Given this list of marker genes PWWP2A, CHD5, H2BC12, PWWP2B (PWWP domain containing 2B), H2AJ, H2BC21, H3C1, CHD3, H2AC14, H2BC3, H2BC14, H2BC17, MBD2, H2BC5, MTA2, H3C15, H2AX (NCBI Gene Id 3014), MTA1, ADNP2, ZNF827, H2AC7, H2AC18, H2AC20, CBX1, H2AC6, ADNP, H2BC15, NR2F2, H3-3A, IKZF3, CDK2AP1, PHF6, MBD3L1, CHD4, G6PC1, H2AC4, H2AB1, H2BC12L, H2BC26, ZMYND8, H2BC9, ZNF687, H2BC4, MBD3L2, H2AZ2, SUMO1, CBX3, HDAC2, MTA3, MBD3, UBE2I, H4C1, ZNF592, IKZF2, NR2C2, RBBP7, CDK2AP2, ZNF532, PCK1, IKZF1, GATAD2B, GATAD2A, HDAC1 (NCBI Gene Id 3065), FBP1, H2BC1, TCF19, RBBP4, H2BC11, H2BC13, here is a description of the gene set: Subfamily II contains the best characterized CHD proteins, CHD3, CHD4 and CHD5. Although these enzymes are capable of hydrolyzing ATP in monomeric form to facilitate chromatin rearrangements, they are best characterized as part of larger macromolecular complexes such as NuRD and ChAPH studied in species Homo sapiens Reactome Pathway: CHD3, CHD4, CHD5 subfamily part of: CHD chromatin remodelers